The following is a description of a gene set: Reactome Pathway: Defective MOGS causes CDG-2b part of: Diseases associated with N-glycosylation of proteins After the lipid-linked oligosaccharide (LLO) precursor is attached to the protein, the outer alpha-1,2-linked glucose is removed by by mannosyl-oligosaccharide glucosidase (MOGS). This is a mandatory step for protein folding control and glycan extension. Defects in MOGS are associated with congenital disorder of glycosylation type IIb (CDGIIb), a multisystem disorder caused by a defect in glycoprotein biosynthesis and characterised by under-glycosylated serum glycoproteins (De Praeter et al. 2000, Voelker et al. 2002). Type II CDGs refer to defects in the trimming and processing of protein-bound glycans. studied in species Homo sapiens, and this is the list of marker genes: MOGS